The following is a description of a gene set: Reactome Pathway: MET promotes cell motility Direct and indirect interactions of MET with integrins, focal adhesion kinase PTK2 (FAK1), tensin-4 (TNS4) and GTPases RAP1 and RAC1, induce morphological changes that promote cell motility and play an important role in HGF-induced invasiveness of cancer cells. species: Homo sapiens part of: Signaling by MET, and this is the list of marker genes: GRB2, FN1 (fibronectin 1), LAMC2, ITGA2, LAMB3, PTK2, COL5A2, LAMC1, HGF, TNS3, COL1A2 (NCBI Gene Id 1278), COL2A1, RAP1A, LAMA1, TNS4, ITGA3, COL1A1, ITGB1, LAMA2, MET, COL3A1, CRKL, COL5A3, RAP1B, COL24A1, GAB1, SRC, LAMA3, CRK, COL5A1, COL27A1, LAMC3, COL11A2, LAMA4, RAC1, DOCK7, COL11A1, LAMA5, LAMB1, RAPGEF1, LAMB2